Given this list of marker genes ZNF138, TOP1, ZNF493, MSL1, PPCDC, VPS45, SDK1, SYNM, SIX4, NAALADL1, ZNF680, ZNF257, CLDN20, PDCD4, ICOS, ZNF716, HACD3, ZNF99, RUFY2, GTPBP2, MBD6, PGM2L1, ATP23, ZNF737, ULBP1, DONSON, NAP1L1, ZNF253, ZBTB38, KCNC3, SMU1, ELMOD2, ZNF506, SHISA9, ZNF732, PIP4K2C, MYEF2, PLPBP, ACIN1, EFNA5, ZNF208, TEK, CAPS2, OPN3, NCL (NCBI Gene Id 4691), PISD, CREBL2, SIRPB1, KIF16B, SLC22A10, here is a description of the gene set: species: Homo sapiens from publication Chen Y, Wang X (PMID 31504780) Genes predicted to be targets of miRBase v22 microRNA hsa-miR-135b-3p in miRDB v6.0 with MirTarget v4 prediction scores > 80 (high confidence targets). Human Gene Set: MIR135B_3P